The following is a description of a gene set: Mouse Gene Set: REACTOME_AMPK_INHIBITS_CHREBP_TRANSCRIPTIONAL_ACTIVATION_ACTIVITY AMPK inhibits chREBP transcriptional activation activity species: Mus musculus, and this is the list of marker genes: Adipor1 (NCBI Gene Id 72674), Adipoq, Adipor2, Prkaa2, Prkab2 (NCBI Gene Id 99943), Prkag2